The following is a description of a gene set: Mouse Gene Set: GOBP_SEMAPHORIN_PLEXIN_SIGNALING_PATHWAY studied in species Mus musculus The series of molecular signals generated as a consequence of a semaphorin receptor (composed of a plexin and a neurophilin) binding to a semaphorin ligand., and this is the list of marker genes: Hand2, Edn1, Sema4g, Sema3b, Gdnf (glial cell line derived neurotrophic factor), Sema6a, Plxnd1, Sema3d, Sema3c, Plxna1, Plxna2, Sema6c, Ednra, Nrp2, Nrp1, Sema3e, Sema5b, Plxna3 (plexin A3), Plxnb3, Mef2c, Sema3f, Trem2, Plxnb2, Plxna4, Sema4f, Sema4a (NCBI Gene Id 99554), Sema6d, Mir23b, Rhoa, Tyrobp, Sema6b, Erbb2, Mir23a, Sema3a, Arhgdia, Sema4b, Plxnc1, Flna (NCBI Gene Id 245705), Farp2, Sema3g, Met, Sh3bp1, Rac1, Crmp1, Ncam1, Sema4c, Mir27b, Sema7a, Mir27a (microRNA 27a), Ece1, Kdr, Sema4d, Plxnb1, Sema5a